Given this list of marker genes GOT1, MDH2, SLC25A11, SLC25A18, MDH1, SLC25A22, SLC25A12, SLC25A13, GOT2, here is a description of the gene set: Human Gene Set: GOBP_MALATE_ASPARTATE_SHUTTLE The process of transferring reducing equivalents from NADH in the cytosol to the mitochondria via malate. Cytosolic aspartate aminotransferase converts aspartate to oxaloacetate, and cytosolic malate dehydrogenase uses NADH to convert oxaloacetate to malate in the cytosol; the malate-alpha-ketoglutarate carrier then transports the malate into the mitochondria where mitochondrial malate dehydrogenase uses NAD to convert malate back to oxaloacetate; the electrons on the reduced NADH are then available for use in the electron transport chain; mitochondrial aspartate aminotransferase converts oxaloacetate to aspartate, and the glutamate-aspartate carrier transports the aspartate back to the cytosol to complete the cycle. species: Homo sapiens